The following is a description of a gene set: Human Gene Set: REACTOME_SYNTHESIS_OF_IP2_IP_AND_INS_IN_THE_CYTOSOL studied in species Homo sapiens Synthesis of IP2, IP, and Ins in the cytosol, and this is the list of marker genes: SYNJ1, MIOX, MTMR7, INPP1, MTMR9, INPP5J, INPP5B, OCRL, IMPA2 (inositol monophosphatase 2), INPP4A, ISYNA1, INPP5A, IMPA1, INPP4B